The following is a description of a gene set: from publication Rivollier A, He J, Kole A, Valatas V, Kelsall BL (PMID 22231304) species: Homo sapiens Genes down-regulated in macrophages versus those sorted as ITGAX int and EMR1 high. Dendritic cells (DCs) and macrophages (MPs) are important for immunological homeostasis in the colon. We found that F4/80hi CX3CR1hi (CD11b+CD103-) cells account for 80% of mouse colonic lamina propria (cLP) MHC-IIhi cells. Both CD11c+ and CD11c- cells within this population were identified as MPs based on multiple criteria, including a MP transcriptome revealed by microarray analysis. These MPs constitutively released high levels of IL-10 at least partially in response to the microbiota via an MyD88-independent mechanism. In contrast, cells expressing low to intermediate levels of F4/80 and CX3CR1 were identified as DCs, based on phenotypic and functional analysis and comprise three separate CD11chi cell populations: CD103+CX3CR1-CD11b- DCs, CD103+CX3CR1-CD11b+ DCs and CD103-CX3CR1intCD11b+ DCs. In non-inflammatory conditions, Ly6Chi monocytes differentiated primarily into CD11c+, but not CD11c- MPs. In contrast, during colitis, Ly6Chi monocytes massively invaded the colon and differentiated into pro-inflammatory CD103-CX3CR1intCD11b+ DCs, which produced high levels of IL-12, IL-23, iNOS and TNF. These findings demonstrate the dual capacity of Ly6Chi blood monocytes to differentiate into either regulatory MPs or inflammatory DCs in the colon, and that the balance of these immunologically antagonistic cell types is dictated by microenvironmental conditions. Human Gene Set: GSE27859_MACROPHAGE_VS_CD11C_INT_F480_HI_MACROPHAGE_DN, and this is the list of marker genes: SFXN3, MARVELD1, VPS11, TTC7A, KIAA0930, MAPK3, ARL8B, PLEKHO1, NEK6, MFSD11, SNAP47, PMS2, ANGPTL2, ARHGAP45, ALDH18A1 (NCBI Gene Id 9193), CAMK2G (calcium/calmodulin dependent protein kinase II gamma), SYNGR1, CCDC167, MOSPD3, C19orf48P, BLOC1S3, GAPT, SLC6A6, CTDSP2, PPP1R12C, DUSP18, MKNK2 (MAPK interacting serine/threonine kinase 2), ZFAND2A, CSGALNACT2, PKN1, WSB2, TTC12, CDK20, ECH1, SOAT1, MRPL41, MAP2K6, ZDHHC9, MEAK7, TMEM214, TLE5, AGL, PPP1CA, ZDHHC14, NPC1, TSPAN14, TPCN1, LPAR5, CORO1C, PTPN7, NCBP2AS2, ANAPC13, SFT2D2, FAM53A, TMEM154, IVD, MRI1, DNAJC9, SLC43A2, SGSM2, MRPL28, CERK, PYCR3, IPCEF1, AP1M1 (adaptor related protein complex 1 subunit mu 1), UAP1L1, MED18, MRPL36, CTNS, KLHL21, FBXO32, IVNS1ABP, C2CD2L, TECR, IDH3G, DUSP7, EIF4EBP2, KMT5C, HINT1, PANK4, BRK1, PDE4DIP, TAF1A, GPX1, AKAP1, LAT2, CD300LB, TCP11L2, NBEAL2, SNAPC5 (NCBI Gene Id 10302), GCSH, SLC25A51, NLRC3, ELOVL5, CDK19, NHSL3, FBXO31, LFNG, RPAIN, DCAF7, MAP3K3, SPACA9, PLIN3, IL6R, NMRK1, TMEM64, NDST1, INPP5K, SMIM12, RIPOR1 (RHO family interacting cell polarization regulator 1), SMYD4, FRG2B, FAM32A, STEAP3, SIPA1 (signal-induced proliferation-associated 1), HPCAL1, CYTH4, DAP, AMD1, SPECC1, CD93, ITPRIPL1, TARBP1, GPSM3, TGM1, XXYLT1 (NCBI Gene Id 152002), ST14, COQ9, SEC22C, NCF2, ACOT2, C22orf39, KLHL6, CDPF1, PDE7B, FAM227A, AGFG2, PCBD2, FBXL6, FADS1, CHEK2, FANCE (FA complementation group E), EMILIN2, RARA, EXOSC5, INPP5A, NARS1, NFIC, GSN, ADIPOR1, MED22, SLC36A1, TSPAN32, XBP1, ADIPOR2, RAB31, SEC24D, USF2, LRRIQ3, RPS6KA1, ATP6V0A1, SORD, BAG4, FAM216A, PDP1, ELOF1, NAGK, LMAN2, DHRS1, TAFAZZIN, CEACAM1 (CEA cell adhesion molecule 1), EIF2B1, PARP1, INTS6L, TSPAN5, RASGRP3, IRF4, ATP6V0D2, RELT, FAM168B, TPM1, KCNN3, TMEM65, LGALS3, MARCHF3, UBALD1, SLC17A9